Given this list of marker genes CAPG, ARHGEF5, MAPK9, RHOA, SRC, MSN, IL5, TNF, CSF2, FSCN1, LCP1, here is a description of the gene set: species: Homo sapiens Any process that activates or increases the rate or extent of podosome assembly. Human Gene Set: GOBP_POSITIVE_REGULATION_OF_PODOSOME_ASSEMBLY